Given this list of marker genes UCN2, ARRDC4, FGF12, SHC3, STK40, FKBP8, PRELID3B, WDFY3, GAPDH, LPP, BMP2, AKAP1, DUSP13B, SLC25A51, LIMK1, USP2, NOL4L, MPRIP, FBXW11, ADORA2A, USP3, ELK3, UBQLN1, RELL2, LIFR, MMP19, IL9, FAP, ABHD2, TBC1D10B, GPR150, STOML2, TRPV3, POLR3E, EPHA2, CA9, MMP7, COL27A1, LYVE1, PCDH9, HSPB7, IL23A, SCOC, UCHL3, HHATL, FERMT3, RTN3, EEF1A1, STX17, BAG2, TRIB1, S100A5, HS3ST3B1, HDAC3, PAX9, ABI3, DCHS1, UBE2C, DIAPH1, GPR3, FHL3, EYA1, RIPK4, CLUH, KLHL41, TEX19, PTPRN, MAP1A, MAPK3, GNGT2, GAB2, AP2A2, SPTA1, ZIC4, HOXA11, BUD31, ZC2HC1C, TUBA1C, AK5, PDAP1, FAM180A, PSMA3, S100A2, CLSTN3, RB1CC1, RABEP1, RBBP7, LAMC1, FAM184A, VIM, TMCC1, ATXN7L2, GNAI1, CACUL1, NECAB3, HOXD3, TNFRSF12A, ZNF385B, LAMB3, PSMD4, TIAL1 (NCBI Gene Id 8430), NFRKB, EIF4E, RNF182, CCDC50 (coiled-coil domain containing 50), XIRP1 (NCBI Gene Id 191580), DSTN, CAMKK1, MYBPH, ZPBP2, PDE4D, TECPR1, CORO1C, IL6, CREM, CAPNS1, RNF144B, ESRRB, USP13, ISG20, CDKN1A, ZIC1, KBTBD8, SLC16A6, PRDM1, CA7, MAP2K1, UBE3A, IGFBP6, PADI3, TCF7, EEF1A2, BACH1, LRRC15, RAP1GAP2, FAM178B, KCNN4, ZNFX1, ROCK2, RAD23B, APOBR, DTX2, DCDC1, SCRN1, TAGLN2, ETV5, TBC1D17, TXN, PAK6, ABCB6, VDR, REXO2, KLHL40, GOLGA4 (NCBI Gene Id 2803), SYNPO (synaptopodin), RPL27A, NRIP3, GGN, EML3, RPA3, PIM2, HPSE2, MDFI, RAPGEF6, XPOT, PITPNC1, TCF12, LTBP3, ROM1, CD151, ZNF436, LAPTM5, PPP1R9B, EIF4G1, EIF3J, CYFIP1, PLEKHH3, BNIP3, KY, SMARCA2, PSMD11, PDGFRB, CLC, EPB41L1, SLC9A5, EDN1, TMEM156, SRPK2, GSN, YIF1A, PLAC1, EVI2B, SLC4A11, ZNF516-DT, WDFY3-AS2, RTN4, MMP9, SH3RF2, LRRFIP2, LMNA (NCBI Gene Id 7816), EFNA1, DNM1, KDM3A (lysine demethylase 3A), LRP1B, RIN1, ANXA7, LAMC2, AP2B1, CILK1, BAZ2A, GJB3, NEFH, FGF11, MAPRE3, ZNF362 (NCBI Gene Id 170467), APOBEC1, PTPRH, IL1RN, ST8SIA5, ZMAT5, ZBTB2, PTPRR, BLMH, CSTPP1, AKT3, TRIM8, C1QTNF8, STAT5B, S100A10, DCTN2, CRYBA2, KCNH2, ATXN7L1, AKT1S1, TENM3-AS1, MAP2, IRAK1, ST18, CCL22, SYTL1, ASS1, NDP, ATXN1, ANKRD28, DDX17, PIANP, CIZ1, PKN3, KRT19, CASK, SFN, CELA1, BTK, ABHD4, ZNF771, RP1L1, RGS8, PLBD2, IL10, AZIN1 (NCBI Gene Id 51582), TMEM151A, KCNH6, TGFBR2, NEK6, CD244, PAPPA, NRAS, AXIN2, CMAS, RUNDC3A, CYTOR, here is a description of the gene set: Genes having at least one occurrence of the motif RGTGACTMANN in the regions spanning 4 kb centered on their transcription starting sites. This matches the JUN transcription factor binding site V$AP1_Q4 (v7.4 TRANSFAC). Human Gene Set: AP1_Q4 studied in species Homo sapiens